The following is a description of a gene set: studied in species Homo sapiens The chemical reactions and pathways resulting in the breakdown of a receptor molecule, a macromolecule that undergoes combination with a hormone, neurotransmitter, drug or intracellular messenger to initiate a change in cell function. Human Gene Set: GOBP_RECEPTOR_CATABOLIC_PROCESS, and this is the list of marker genes: GIT1, ABCA2, BECN1, LAPTM5, NEDD4L, GPRASP1, CDK5, PCSK9 (proprotein convertase subtilisin/kexin type 9), BECN2, MVB12A, PIK3R4, DTX3L, CAPN1, NEDD4, UVRAG, RNF43, SMURF1, APOE, ZNRF3, SH3GLB1, HAMP, FURIN, MTMR2, KIF16B, TGFB1, PTPN1, ANXA2, MYLIP, SNX25, ITCH, LGMN